Given this list of marker genes CBL, TRPS1, ABL1, NR1H4, CEBPE, SERPINF1, ENPP1, TREX1, GATM, SLC39A4, TMEM38B, TNFRSF11B, USP53, HNRNPA1, PIGB, IARS1, PGAP2, CLDN16, CALR, TCF4 (NCBI Gene Id 6925), FGF23, PIGW, MPV17, SPIB, TP53, IFT56, ALPL, STX5, TFAM, SLC51A, SLC25A13, PEX2, APOA1 (NCBI Gene Id 335), PIGG, TNFRSF11A, SC5D (sterol-C5-desaturase), SLC37A4, COG6, SEMA4D, PIGL, PKD2, PIGQ, CCDC47, CYP27B1, SLC34A1, PLEKHM1, CSF3R, LRRK1, MMEL1, CCDC115, JAK2, VDR, PANK2, HNF1B, IRF5, PRKCSH, HNRNPA2B1, TNPO3, RUNX1, NPR2, IL12RB1, KIF12, ESR1, BCR, IL12A, VCP, ELMO2, NPR3, TRPV6, PIGV, C18orf32, HMGCR, PIGT (NCBI Gene Id 94004), RB1, LRP5, DMP1, GPR35, SOST, SGMS2, SEC63, PIGA, CYP7B1, LIPA, CTNS, PKHD1, FAM20C, TMEM199, SRSF2, MST1, CHEK2, PIGF (NCBI Gene Id 5281), ACVR1, COG4, GNPNAT1, SLC2A2, TMEM67, PIGY, CYP3A4, ABCB4, AKR1D1, CLCN7, PIGH, ABCB11, ASXL1, PIGS, FKBP10, TEFM, PHEX, LBR, SLC4A2, SLC34A3, TCIRG1, F5, DCDC2, PIGU, ATP8B1, ANKH, PIGO, SIK3, PIGK, GPAA1, TNFSF15, PRIM1, SQSTM1, BCS1L, POU2AF1, HNF4A, PTH1R, PIGC, ABCC6, BGN, PGAP3 (post-GPI attachment to proteins phospholipase 3), TET2, CYP2R1 (NCBI Gene Id 79445), ZNF687, GALNT3, here is a description of the gene set: Human Gene Set: HP_ABNORMALITY_OF_ALKALINE_PHOSPHATASE_LEVEL An abnormality of alkaline phosphatase level. Abnormality of alkaline phosphatase level species: Homo sapiens